The following is a description of a gene set: Human Gene Set: GOCC_CONE_PHOTORECEPTOR_OUTER_SEGMENT The outer segment of a vertebrate cone photoreceptor that contains membrane discs that are contiguous with the ciliary membrane and containing opsin photoreceptor proteins. species: Homo sapiens, and this is the list of marker genes: GUCA1B, PCARE, RD3, IFT140, GUCA1ANB-GUCA1A, GUCA1A, SLC24A4, OPN1SW, TMEM237